The following is a description of a gene set: from publication Elo LL, Järvenpää H, Tuomela S, Raghav S, Ahlfors H, Laurila K, Gupta B, Lund RJ, Tahvanainen J, Hawkins RD, Oresic M, Lähdesmäki H, Rasool O, Rao KV, Aittokallio T, Lahesmaa R (PMID 20620947) Human Gene Set: GSE17974_0H_VS_12H_IN_VITRO_ACT_CD4_TCELL_UP Genes up-regulated in comparison of untreated CD4 T cells at 0 h versus the untreated cells at 12 h. The aim of this dataset was to study in detail the transcription kinetics initiated by cytokine IL-4 in early differentiation of Th2 cells. studied in species Homo sapiens, and this is the list of marker genes: PARP8, KCNA3, STK16, FAM8A1, ZNF844, ADCY5, CNST, NFKBIZ, ITGA6, CRAMP1, TENM1, OVGP1, PIM1, C16orf74, BIN2, KIFC2, EPHA4, C4BPA, SPTBN1, PLCXD2, TIGD1, FOS, TXK, LINC00173, FAM200B, APRG1, SUSD3, HCST, GPR65, CLEC7A, MYLIP, ST7L, DIAPH2, KLF11, ASH1L-AS1, PLEK, TP53INP1, PDE2A, ISCA1, HELZ, RAP1GAP2, ITCH, ZNF711, ARIH2OS, UBE2Q2P13, MEF2D, CRIP1, PPP3CA, AK5, RBSN, CKAP2, CTSK, NMRK1, LINC00938, TCF7L2 (NCBI Gene Id 6934, transcription factor 7 like 2), SYNM, BIN1, GABBR1, SMAGP, PTPRM, GOLGA7B, RASGRP2, REM2, C9orf72, MXI1, ZNF101, FAM111A (FAM111 trypsin like peptidase A), PPP3CC (NCBI Gene Id 5533), NR4A2, GPRASP2, KLHL3, USF3, ZNF8, TMEM156, ZNF552, KRTAP1-1, KCTD3, MICAL1, TSPYL4, TSC22D1, GTF2IRD2, SRSF1, RNF125, SNX29, SOX4, NR1D2, HEG1, MAP4K4, CAPN2, SUSD1, PSTK, ITGA4, MBNL2 (NCBI Gene Id 55479), H2AJ, ITPRIP, AUTS2, TPM2, PELI2, LINC01127, ASAH1, LINC02035, LYRM9, PERP, HYKK, MYO1G, AGTPBP1, MDS2, TMIGD2, CERS6, ARRDC3, SERINC5, PDE4D, FNIP1, SUSD4, COQ10B, AQP3, FHIT, SOCS3, OTUD1, SIGIRR, DPEP2, PITPNC1, HKDC1, ATXN1L, SLC2A3, FBXO33, FAM204A, FAM228B, ZNF256, NAP1L5, CD3G, SC5D, GABARAPL1, STAG3L4, PTP4A1, HEBP2, MYO1F, ZBTB4, MXD1, DENND5A, ZFAND2A, PKIG, UBASH3B, TTC32, PDCD6P1, IER2, TRAPPC13, GARS1-DT, PNMA3, KRT73, ST3GAL5, DUSP1, NDRG1, SORL1, ATG14, IL11RA, SYTL1, TTLL13, GPR183 (NCBI Gene Id 1880), LINC02223, ANKRA2, ZNF329, FOSL2, RNF10, CFL2, MAFF, SCARNA17, KLF4, UTRN, TOB1, F11R, DNAJB9, MINDY2, ZDHHC11 (zinc finger DHHC-type containing 11), ZNF34, ZBTB20, PBX4, YPEL5, PCSK5, IRS2, DRAM2, SKIL, RBM33, S100A10 (NCBI Gene Id 6281), LINC01720, PNPLA8, AHNAK, NET1, ZNF592, GKAP1, IRF2BP2, FCMR, CSGALNACT1 (NCBI Gene Id 55790), VIPR1, NSMCE3, PCNT (pericentrin), PDCD4-AS1